The following is a description of a gene set: Genes predicted to be targets of miRBase v22 microRNA hsa-miR-6830-3p in miRDB v6.0 with MirTarget v4 prediction scores > 80 (high confidence targets). from publication Chen Y, Wang X (PMID 31504780) species: Homo sapiens Human Gene Set: MIR6830_3P, and this is the list of marker genes: ZMYM4, PCDHA7, TANC2, SATB2, PCDHA4, SEC61A2, MT1B, TFPI, TTC14, TMEM196, COL4A1, INA (internexin neuronal intermediate filament protein alpha), QSER1, TRMT11, UBE2H, CREBZF, ITGB1, UGT3A2, DDX5, KLHL4, PIK3C2G, PPFIA2, PAPPA, IQCJ, FOXA1, DUSP7, FOXR2, HSDL1, POLR2H, KHDRBS2, C6orf120, ADAM33, TMEM123, UBE2D1, TRPC5OS, MRTFB, PCDHA1, TRAF6, PFN4, EEIG2, BTN2A2, GTF3C3, DEPDC1B, TUB, DISC1, TNRC6C, CEP126, PCDHA5, MYEF2, POU4F2, CNTN1, IGF2BP1, PDZD8, ENPP4, LSM14A, IGDCC4, RFPL4B, POGZ, THBS1, DHX40, LRRK2, AQP4, CD83, PDPN, MAP4K4, PRKAR1A, RYBP, CXCL10, DNA2, PCDHA12, MINK1, LATS1, PCDHA13, SULT4A1, EGR3 (NCBI Gene Id 1960), ST6GAL2, ERBB4, TMEM140, HMGA2, KLF9, EML6, PAX8, FNBP1L, SLC22A15, CREM, PRRT1, RNF19B, ELMOD2, PCDHA10, MTAP, MAP3K2, USP8, TCP11L2, UXS1, MORC1, MIER1, CD36, AKIRIN1, POTEM, ATRNL1, CCDC126 (coiled-coil domain containing 126), ADGRF5, UNKL, KCNK9, CD93, DCAF8, BACH2, TRDN, NRG1, KCNAB3, ZNF813, TSPAN7 (tetraspanin 7), PCDHA9, PCDHA3, OSBPL9, HECTD2, PLSCR1, PCDHA2, SMIM6, EPHB2, NFIC, SMARCA5, CCSER2 (NCBI Gene Id 54462), PHKA2, NTRK2, ABO, SLC24A2, MTERF3, CADM2, CTDSPL2, NAIF1, SLC5A12, RAP1GDS1, SLC22A17, PCDHA6, SLITRK1, KHDC1, PITX2, LEPROT, PCDHAC2, ABR, CTSC (NCBI Gene Id 50958), SYT11, DPP10, PLA2R1, TUT7, RAPGEF6 (Rap guanine nucleotide exchange factor 6), TSHZ1, EIF4H, ATP8B1, GAB3 (NCBI Gene Id 139716), PCDHAC1, ZNF765, GPR156, CCSER1, OPN5, FLG2, HLTF, SOX6, HAS2, MTNAP1, FN1, CCAR1, DUSP6, KCNC4 (potassium voltage-gated channel subfamily C member 4), OLR1, NUMB, PCDHA11, FUT9, TGFBR1, ALCAM, SCN9A, TNRC6B, PRKG1, SPTLC3, HRNR, NCR3LG1, MYCBP, KLHL31, IL36B (interleukin 36 beta), DIO2, DCUN1D5, CHGB, TBC1D22B, SPTLC2, ERICH1, HHLA1, ZNF800, KLB, TIMM21, IL12RB2, CREB1, TMEM47, MTM1, ZNF468, GDA, TP53INP1, SERTAD2, ABCF1, PRDM7, BTLA, CYP4F3, RAPGEF2